Given this list of marker genes HES5, EZH2, MSX2, REG3G, OVOL2, EXTL3, SRSF6, DLL1, TP63, NOTCH1, REG3A, HES1, HOXA7, GDF3, here is a description of the gene set: studied in species Homo sapiens Any process that stops, prevents, or reduces the frequency, rate or extent of epidermis development. Human Gene Set: GOBP_NEGATIVE_REGULATION_OF_EPIDERMIS_DEVELOPMENT